The following is a description of a gene set: species: Homo sapiens Human Gene Set: REACTOME_DEFECTIVE_LFNG_CAUSES_SCDO3 Defective LFNG causes SCDO3, and this is the list of marker genes: LFNG, NOTCH3 (NCBI Gene Id 791), NOTCH2, NOTCH1, NOTCH4